Given this list of marker genes PTCHD3, LUZP4P1, MIR1915HG, MRM3P1, ENSG00000240291 (NCBI Gene Id 124902386), ENSG00000307553, PIP4K2A, TRIAP1P1, MRC1, NEBL, PRTFDC1, RNA5SP305, RN7SKP220, LINC02643, ENSG00000223027, ST8SIA6-AS1, MSRB2, PRPF38AP2, ST8SIA6, RPL21P93, LINC02652, LINC02680, SPAG6, RNU6-946P, ENSG00000285254, ZNF101P1 (NCBI Gene Id 100419867), BMI1, ACBD5, PLXDC2, RNA5SP304, RNU7-12P, CACNB2, RN7SKP132, BAMBI, AMD1P1, SELENOOLP, HIRAP1, RNU6-1067P, LINC03028, NSUN6, APBB1IP, AIFM1P1, MTND2P16, MYO3A, ARL5B, MTND1P21, LINC01516, GPN3P1, SLC39A12-AS1, RNU6-1141P, C10orf67, DNAJC1, RNU2-24P, MIR511, STAM, WAC-AS1, FAM210CP (family with sequence similarity 210 member C, pseudogene), ADIPOR1P1, FAM238A, RNU6-270P (NCBI Gene Id 106479686), OTUD1, NUP35P1, GPR158, YME1L1, MPP7, C10orf67-AS1, RN7SKP241, LINC01517, ENSG00000234244, THNSL1, FAM238C, ENSG00000285852, GPR158-AS1, SKIDA1, RN7SKP219, ODAD2, ODAD2P1, RAB18, ENSG00000200545, MASTL, ENSG00000222666, RNA5SP306, PSME2P6, ENKUR, MIR8086, HMGN1P20, RNU6-1212P, MIR1915, MKX-AS1, LINC00837, RNU6-15P, HNRNPRP1, KIAA1217, HSPA8P3, RPL36AP55, MRPS21P5, LINC00836, RNU6-306P, ANKRD26, STAM-DT, ABI1, MALRD1, LRRC37A6P, RNA5SP303, RNU6-413P, ENSG00000233968, MIR603, MIR4675, NPM1P30, TPRKBP1, COMMD3-BMI1, PTF1A, RNA5SP307, YWHAZP3, EIF4BP2, RNU6-490P, COMMD3, MLLT10, RNA5SP308, LINC02673, RN7SKP37, RN7SKP39, RNU4ATAC6P, MKX (NCBI Gene Id 283078), RPSAP10, RNU6-452P, LYZL1, FAM238B, SLC39A12, RPL31P45, RNU6-666P, RNU6-632P, GAD2, EBLN1, ARMC3, ENSG00000235020, WAC, HACD1, NEBL-AS1, MPP7-DT, PDSS1, UBE2V2P1, ARHGAP21, ENSG00000304441, MTND1P37, ENSG00000297866, TMEM236, here is a description of the gene set: studied in species Homo sapiens Human Gene Set: chr10p12